The following is a description of a gene set: Genes down-regulated in comparison of control dendritic cells (DC) at 24 h versus those stimulated with CpG DNA (TLR9 agonist) at 24 h. studied in species Homo sapiens Human Gene Set: GSE17721_CTRL_VS_CPG_24H_BMDC_DN from publication Amit I, Garber M, Chevrier N, Leite AP, Donner Y, Eisenhaure T, Guttman M, Grenier JK, Li W, Zuk O, Schubert LA, Birditt B, Shay T, Goren A, Zhang X, Smith Z, Deering R, McDonald RC, Cabili M, Bernstein BE, Rinn JL, Meissner A, Root DE, Hacohen N, Regev A (PMID 19729616) mouse primary BMDCs were stimulated with tlr ligands and gene expression changes were profiled on Affymetrix arrays, and this is the list of marker genes: STRADA, TBCB, MAGOHB, PI4K2A (NCBI Gene Id 55361), NSUN2, SPON2, SLC25A53, SATB2, MTAP, PSMB8, BLOC1S6, TSPAN33, SLC22A7, ZNF821 (NCBI Gene Id 55565), TRIM54, MAP4K2, POU3F3, WFDC1, OGDH, LRRC59, PHF8, RPE, MCM3, SUGP2, MYO1B, PTPRG, TJP2, KPNA6, SLC22A6, PRG2 (proteoglycan 2, pro eosinophil major basic protein), MYB, SRSF9, PREB, ZNF276, RAD23B, PEX2, RBMX2, UBE2N, ZCCHC10, PI16, NPPC, MUTYH, USP26, TMIGD1, TAGLN2, MARCKSL1, MCM5, RRP12, STIMATE, NBEA, WDR54, PRKCQ, SMYD5, TSC2, ORC3, PTPN4, TOR1B, TNFRSF1B, VTI1A, OLFML3, TOX, TTLL1, SLC7A8, CACNG6, MID2, PSMD4, MTERF4 (mitochondrial transcription termination factor 4), RECQL5, ELOC, YWHAE, NUB1, RNPS1, USP14, KIT, PEX19, TXNDC9, TP53BP1, MMP1, RDH16, TNFRSF8, YES1, THBS4, ZNF445, QRICH1, NUP188, UGT2A3, SS18L2, ZNF639, TCERG1, RRBP1, POLE2, TOMM40, TUBGCP5, KIF3B, RPF2, NAB1 (NGFI-A binding protein 1), PRKCSH, SPRY2, ZNF207, MYL9, NPY4R, TUB, PDZRN3, PARG, TCP1, MYF5, WIF1, OTP, NUDC, TMEM167A, PURB, TNFRSF14, PTBP1, SRSF2, ZMYM1, SRPRA, STX1A, LY96, POLR2F, MTF2, SNX10, EFEMP2, MRPS25, NUDT9, LYRM2, RAD51C, SCN11A, RAG1, GEMIN2, TPI1, TLL2 (tolloid like 2), MRM1, MTF1, SRPX2, PTN, LIPT1, VASN, SYT12, PNPT1, SH3D19, RCC1, SFTPC, NRARP, ROCK1, NOP2, TFPI, SHH, SLC17A3, IFT22, POLR2K, TBX21, SKAP2, PGF, RGS20, TPRKB, MOGS, PAPSS1, ONECUT3, PPP2R3A, TMEM106B, PTPN2, ZBP1 (Z-DNA binding protein 1), NEK6, SAR1B, TMEM115, TNFAIP6, THAP7, RYK, TAL2, TMEM106C, TIMP1, SEMA3B, MAP2K3, MRFAP1L1, MOB4, PACRGL, MMP17, MRPL12, RNF20, TUBB4A, TMED3, VCAM1, SMAD1, PTPRE, TP53RK, RIN1, YARS1, SLC34A2, PUS3, TTK, RAB14, PSMB9, SLC27A1, RBM26, MRI1, PAFAH1B2, KRT32, STMN3, RDH10